The following is a description of a gene set: studied in species Homo sapiens Human Gene Set: GOBP_WYBUTOSINE_METABOLIC_PROCESS The chemical reactions and pathways involving wybutosine, 3H-imidazopurine-7-butanoic acid, 4,9-dihydro- alpha-- 4,6-dimethyl-9-oxo- 3-beta-D-ribofuranosyl methyl ester, a modified nucleoside found in some tRNA molecules., and this is the list of marker genes: TRMT12, TYW1, TYW5, TYW3, TYW1B, LCMT2